Given this list of marker genes EPM2AIP1, PPP1R3B (protein phosphatase 1 regulatory subunit 3B), IGF1, AKT2, DYRK2, PPP1R3E, PPP1CA, INS, ADCY10, IRS1, IRS2, PHKG2, GCK, IGF2, INSR, PPP1R3G, PHKA1, HMGB1, SORBS1, PTH, AKT1, here is a description of the gene set: Any process that activates or increases the frequency, rate or extent of the chemical reactions and pathways involving glycogen. Human Gene Set: GOBP_POSITIVE_REGULATION_OF_GLYCOGEN_METABOLIC_PROCESS species: Homo sapiens